The following is a description of a gene set: species: Mus musculus Mouse Gene Set: GOBP_REGULATION_OF_LEUKOCYTE_DIFFERENTIATION Any process that modulates the frequency, rate or extent of leukocyte differentiation., and this is the list of marker genes: Cbfb, Cd27, Nckap1l, Kitl, Prdm16, Tgfbr2 (transforming growth factor, beta receptor II), Esrra, Cd74, Fos, Shb, Rc3h1, Pbrm1, Egr3, Skint1, Ihh, Ikzf1, Mir150, Sox12, Il1rl2, Duxbl1, Gli3, Zfp608, Drosha, Hmgb1, Trem2, H2-Oa, Pf4, Ikzf3, Ager, Jun, Pla2g3, Qki, Ccr2, Ascl2, Slc4a2, Apc, Evi2, Gfi1b, Vnn1, Actb, Flt3, Ripk1, Nkap, Hspb1, H2-M3, Vsir, Sh3rf1, Loxl3, Tesc, Sh2b3, Zbtb46, Rc3h2, Malt1, Id2, Tal1, Tmem131l, Inpp4b, Foxo3, Zap70, Il20, Phf10, Prkdc, Cd101, Ap3d1, Lag3, Tyrobp, Adrm1, Pik3r6, Il2ra, Eeig1, Lilrb4b, Ccr7, Smarcb1, Zfp609, Cdkn2a (cyclin dependent kinase inhibitor 2A), Ifng, Ninj1, Pglyrp3, Ccr1l1, Tox, Gnas, Myc, Tescl, Cyp26b1, Cd28, Smarcd3, Csf1, Rbp1, Tmem64, Ccl5, Zfp683, Zeb1, Ap3b1, H2-Aa, Pglyrp1, Nme2, Il18, Kat5, Ptpn2, Cd24a, Lilrb4a, Itpkb, Brd2, Lgals1, Gimap3, Gas6, Nedd9, Iapp, Cdk6, Runx3, Pik3r1, Nf1, Ptprc, Itgam, Wnt10b, Fshr, Tnfrsf11a, Foxj1, Prdm1, Csf1r, Il15, C1qc, Gpr137, Actl6b, Abl1, Socs1 (suppressor of cytokine signaling 1), Tcf7, Hsp90aa1, Tgfb1, Ifnb1, Il3, Il4i1, Flt3l, Tnfsf18, Slc46a2, Erfe, Traf6, Fas, Gpr68, Tnfaip6, Zbtb1, Tjp2, Ada (NCBI Gene Id 11486), Cd69, H2-Ea, Il23a, Ccl3, H2-DMa, Sos2, Il2, Ppargc1b, Fshb, Brd4, Smarce1, Foxn1, Fbxw7, Il5, Carmil2, Tbx21, Smarcc2 (NCBI Gene Id 68094), Ccl9, Pou4f2, Lck, Casp8, Lgals9, Lrrc17, Mitf (NCBI Gene Id 17342), Slc9b2, Atp11c, Runx1, Mir301, Prdx2, Tmem178, Stat5b, Adam8, Cul4a, Bad, Il12a, Tnfsf11, Hoxa7, Hsf1, Pira12, Pilrb1, Slamf8, Ankle1, Lef1, Hcls1, Xbp1, Zbtb7a, Cldn18, Opa1, Rhoa (ras homolog family member A), Ambra1, Sfrp1, Asxl2, Cd46, Btn2a2, Actl6a (actin-like 6A), Bmp4, Crtam, Cd4, Xrcc6, Syk, Rorc, Nfkbid, Gsk3b, Tmem176b, Tmem176a, Rag2, Rassf2, Mtor, Il21, Ubash3b, Evi2b, Prkca, Smarca2, Il2rg, Trib1, Ccl19, Il36b, Il6, Pias3, Cebpb, Card11, Dtx1, Mdk, Ltf, Pnp, Cd1d1, Zc3h8 (NCBI Gene Id 99204), Smarca4, Klhl25, Smarcd2, Smad7, Dcstamp, Tlr9, Cyld, Cd44, Cartpt, Klf10, Foxp3, Notch2, Bcl6, Gpr137b, Gpr55, Kat2a, Hlx (H2.0-like homeobox), Zfpm1, Mir223, Zfp36l2, Zbtb7b, Ccr1, Tnfsf4, Fanca, Tnfsf9, Inpp5d, Ccr6, Spi1, Nrarp, Zfp36l1, Ocstamp, Clec2g, Mir326, Gimap5, Clptm1, Arid1a, Kcnk18, Rara, Ctla2a, Il7, Pck1, Il4, Rnf41, Sox13, Pglyrp4, Dlk1, Clec2d, Socs5, Cd40lg, Jak3, Lif, Stat5a, Prkcz, Tob2, Acin1, Gata2, Nfam1, Il34, Hax1, Nlrp3, Nfkbiz, Ptpn6, Irf1, Ripk2, Tnf, Ccl20, Thoc5, Braf, Nme1, Tnfrsf11b, Il15ra, Clec12a, Pira1, Shh, Tcta, Sos1, Prxl2a, Cd83, Mettl3, Ppp3ca, Smarcd1, Ctnnbip1, Foxp1, Rag1, Ctla4, Zfp35, Il12b, Ror2, Fadd (Fas associated via death domain), Pglyrp2, Axl, Il7r, Zmiz1 (zinc finger, MIZ-type containing 1), Il4ra, Il17a, Ep300, Dicer1, Ndfip1, Gata3, Fbxo7, Fgl2, Pou4f1, Ddrgk1, Arid2, Car2, Creb1, Fes, Pcid2 (PCI domain containing 2), Mafb, Mmp14, Rhoh, Dusp10, Hmgb3, Lyn, Sart1, Rptor, Ceacam1, Il27, Fgfr3, Anxa1, Zc3h12a, Clec2i, Clec4g, Fstl3, Fbn1, Sash3, Bmyc, Apcs, Adipoq, Brd7, Il10, Tfe3, Ctnnb1, Itgb3, Smarcc1, Ppp2r3c (NCBI Gene Id 80481), Erbb2, Tespa1, Rasgrp1, Fancd2, Prelid1, Sox4, Rb1